Given this list of marker genes ADAM8, TJP2, TCIM, TNNI2, NDUFAF4, SLC45A3, CD300LF, MARCHF5, RUFY1, COPRS, PSME4, TM6SF2 (NCBI Gene Id 53345), IGF2BP1, DENND5A, FRMD4B, KHDC1L, IGF2BP3, TCEAL8, GADD45G, PNO1, FGA, FLNB, DARS1, CTTN (NCBI Gene Id 2017), ECHDC2, HIF3A, NKAIN1, CLDN2, HOMER2, RHOV, ID2, VCL, IGF2, ANAPC4, INSL5, FFAR2 (free fatty acid receptor 2), PGAM1, GNAT2, SPECC1, NRARP, C3orf70, CLDN4, PODXL, ZNF14, EPDR1, CYSLTR1, EGLN3, NKAP, PTPN14, SEPHS2, GZMA, XPOT, KLF4, GEMIN6, TOM1L1, NANP, TIRAP, CCDC102A, COPS3, TPP2, TRIP12, BMPR1A, GOLPH3, ROBO1, FBXO15, SCD, SPATS2, FBLN1, GDI2, PSTPIP2, EFCAB2, DSP, CAPN2, POLM (DNA polymerase mu), NLRP6, HK2, RPL39L, GNPNAT1, REG3G, MEIS1, MRPL42, GCSH, BMAL1, NRDC, ACYP2, PMFBP1, ZCCHC3, BEX1, NSF, PGM1, BEX4, SKP1, HMGA2, MRPL22, CLNK, GZMB, EPHX2, IL4, CD160, CENPV, RNF32, VAPA, ABCE1 (ATP binding cassette subfamily E member 1, NCBI Gene Id 6059), NSDHL, BCAT1, SLC39A11, CFHR2, GPX8, COL18A1, NDRG2 (NDRG family member 2), RFLNB, TMEM126A, HNF4A, FDX1, SUV39H2, NCAM1, UCHL3, UQCRFS1, ARAP3, PLPP1 (NCBI Gene Id 94702), GORASP2, IL5RA, GPC3, LTA, RBP1, PGAM2, TRIM13, PHACTR2, CDR2, BZW2, RCOR2, H19, GFM1 (G elongation factor mitochondrial 1), GK, EPRS1, PTPN13 (NCBI Gene Id 5783), BID, SEMA3C, IARS1 (isoleucyl-tRNA synthetase 1), MT1E, HSPH1, PTK2 (NCBI Gene Id 5747), FSCN1, SLC25A53, ARMT1, MYO5C, B4GALNT2, MAPK13, FKBP1B, IFTAP, BEX2, FBP1, NAF1, PARP2, GAL, NUP93, FASTKD1, TES, GATA1, ANG, TIMM23, PTPN12, CTBP2, NRK, CHD7, CS, NFKB1, SLC16A1, CLBA1, CLVS1, BASP1, H3C4 (NCBI Gene Id 8351), GRB10, U2SURP, SUB1, RAD17, MORC4, PLEKHA5, SERPINC1, GOLM1, PPIC, LYAR, MED7, ASNS, PCBP4, CA8, TMEM167A, DSG2, RNF128, AGFG1, SLC16A7, APOE, CRTAC1, SEPTIN8, GGT1, TRIM6, ZNF518B, TXK, LSR, DUSP1, here is a description of the gene set: from publication Belyaev NN, Biró J, Athanasakis D, Fernandez-Reyes D, Potocnik AJ (PMID 22581009) Human Gene Set: GSE24142_ADULT_VS_FETAL_DN2_THYMOCYTE_DN Genes down-regulated in comparison of adult DN2 thymocytes versus fetal DN2 thymocytes. Development of T-cells provides a unique opportunity to study cell-fate determination due to the accessability and the well defined stages of developmental stages. In order to understand the genetic programs underlying fetal and adult T‑cell fate specification we subjected highly purified fetal and adult T-cell progenitor populations to a genome‑wide transcriptional analysis. The aim was to identify molecular elements that govern T-cell fate specification as a whole but ultimately to isolate elements that were specific for a given population in a specific developmental window. studied in species Homo sapiens